Given this list of marker genes GZF1, RNU4ATAC, KIF22, CHST3, B3GALT6, EXOC6B, GNB2, THBS2, B3GAT3, here is a description of the gene set: Dislocation of many joints. species: Homo sapiens Human Gene Set: HP_MULTIPLE_JOINT_DISLOCATION Multiple joint dislocation